The following is a description of a gene set: Genes upregulated in subsets of cells of a given type within various tumors species: Homo sapiens Human Gene Set: GAVISH_3CA_MALIGNANT_METAPROGRAM_3_CELL_CYLCE_HMG_RICH from publication Gavish A, Tyler M, Greenwald AC, Hoefflin R, Simkin D, Tschernichovsky R, Galili Darnell N, Somech E, Barbolin C, Antman T, Kovarsky D, Barrett T, Gonzalez Castro LN, Halder D, Chanoch-Myers R, Laffy J, Mints M, Wider A, Tal R, Spitzer A, Hara T, Raitses-Gurevich M, Stossel C, Golan T, Tirosh A, Suvà ML, Puram SV, Tirosh I (PMID 37258682) In this study, an extensive analysis was conducted to define meta-programs (MPs) capturing intra-tumor heterogeneity across a spectrum of tumor types. The approach utilized non-negative matrix factorization (NMF) to analyze each cell type separately within individual tumor samples. This involved the analysis of malignant cells, macrophages, fibroblasts, endothelial cells, epithelial cells, T-cells, and B-cells. NMF was executed with varying parameter values (K=4, 5, 6, 7, 8, 9), thereby generating 39 programs for each cell type per sample. Each NMF program was summarized by the top genes based on NMF coefficients.\nRobust MPs were then delineated for each cell type using a set of stringent criteria, including recurrence within the same tumor, similarity to programs in other tumors, and non-redundancy within a tumor. Subsequently, these robust NMF programs were clustered (per cell type) based on Jaccard similarity, leading to the identification of MPs associated with each cell type.\nTo enhance the quality of the MPs, a refinement steps were undertaken, involving the removal of MPs suspected of reflecting low-quality data (with an overrepresentation of ribosomal proteins or mitochondrial-encoded genes), single-study inclusion, or similarity to miss-annotated cell types., and this is the list of marker genes: SNRPB (small nuclear ribonucleoprotein polypeptides B and B1), IFT25, NUCB2, HMGB2, TPI1, ANAPC11, HSPE1, ATP5MC1, TUBB, H2AZ2, NAA38, DUT (deoxyuridine triphosphatase), YBX1 (NCBI Gene Id 7806), SIVA1, PCNA, TYMS, HMGA1, MIF, RAN, H2AZ1, HMGB1, ANP32B, HNRNPA2B1, ATP5MC3 (NCBI Gene Id 518), COX5A, STMN1, SNRPD1, RANBP1, SNRPF, TK1, LSM4, SUMO2, SNRPD3, HMGN2, SNRPG, COX8A, UQCRQ, ERH, H4C3, MCM7, PCLAF, SRSF7, SNRPE, SLIRP, HMGN1, TUBA1B, NME1, CKS1B, HSPD1, SLC25A5